The following is a description of a gene set: The process in which a protein translocates through the ER membrane posttranslationally. Mouse Gene Set: GOBP_POST_TRANSLATIONAL_PROTEIN_TARGETING_TO_MEMBRANE_TRANSLOCATION studied in species Mus musculus, and this is the list of marker genes: Glp1r, Sec61a1, Sec61g, Sec61a2, Hspa5, Sec61b, Sec62, Sec63